The following is a description of a gene set: Human Gene Set: GOBP_REGULATION_OF_MICROTUBULE_CYTOSKELETON_ORGANIZATION studied in species Homo sapiens Any process that modulates the frequency, rate or extent of the formation, arrangement of constituent parts, or disassembly of cytoskeletal structures comprising microtubules and their associated proteins., and this is the list of marker genes: HAUS5, TPR, HSPA1B, RHOA, MARK2, FGF13, CHMP4B, NUP62, HDGFL3, MAPRE2, CHMP2B, HAUS6, FAM107A, CAV3, SPAST, SASS6, CDK2AP2, CIB1, CDK5R1, DRG1, MAP6D1, CAMSAP2, BORA, STIL, CHMP5, BICD2, HAUS4, APC2, GSK3A, NME7, MAP1S, RAE1, EPHA3 (EPH receptor A3), KIF18A, PHLDB1, MAPRE1, OCLN, DIAPH3, CHMP2A, PARP3, ARL2, MAPK15, HAUS1, TAOK1, CAMSAP1, PRKAA2, RIPOR2, CDH5, TACC3, SNCA, GNAI1 (G protein subunit alpha i1), PSRC1, HDAC6, GAS2L1, BBOF1, SKA1, TBCD, GSK3B, KATNB1, CHMP1A, ATXN7, CHMP6, DYRK1A, PAFAH1B1, MAPT (microtubule associated protein tau), SLAIN2, MID1IP1, CEP97, HAUS7 (HAUS augmin like complex subunit 7, NCBI Gene Id 55559), CHMP4A, PRUNE1, DIXDC1, CDK5RAP2, PRKAA1, MAP1A, AURKB, MAP9, SPEF1, MID1, FSD1, TUBB4A, SPECC1L, TRIM36, STMN4, CLTC, VPS4B, ARHGEF7, ARHGEF2, ATAT1, TPX2, CAMSAP3, CLIP3, AKAP9, CLASP1, CHMP4BP1 (charged multivesicular body protein 4B pseudogene 1), CCSAP, MAP1B, TRPV4, TRAF3IP1, PPP2CB, TPPP, CEP70 (centrosomal protein 70), STMN1, CHMP1B, ABL1 (ABL proto-oncogene 1, non-receptor tyrosine kinase), STMN3, CCDC88C, EML2, MET, PAK1, SKA3, PDE4DIP (NCBI Gene Id 9659), GAS2L2, KIF21A, MAP6, ANKRD53, APC, BICD1, WDR47, ROCK1, HNRNPU, BMERB1, TOGARAM1, EFNA5 (ephrin A5), PHLDB2, RAC1, HSPA1A, SLC39A12, CLASP2, CKAP2, HAUS3, GBA2, SPAG5, RCC1, SKA2, CENPJ (centromere protein J), FES, MAP2, TRIM54 (tripartite motif containing 54), CLIP1, CHMP7, MECP2, HAUS2, CDKN1B, CKAP5, GPSM2, TTBK2, INPP5J, RNF4 (NCBI Gene Id 6047), PKD1, SLAIN1, GIT1 (NCBI Gene Id 28964), RPS3, PLK1, WNT3A, PDCD6IP (NCBI Gene Id 245794), EML3 (NCBI Gene Id 256364), NAV3, DYNC1H1, FKBP4, NUMA1, SENP6, STMND1, PPP2CA, CHMP3, CHMP4C, DCTN1, STMN2, HAUS8 (HAUS augmin like complex subunit 8), MAPRE3, CYLD